Given this list of marker genes CCL19, NFKB2, REM1, BATF, IQSEC2, PSME2, STAG1, ZNF189, SAP30, HEG1, STOM, FAM131A, NME4, ZNF254, FOSL2, CCL8, USP11, TWIST1, THEMIS2, IDO1, DLEC1, IFITM1, IL6, LILRB2, HTRA1, RPL13P5, DYNLT1, HMBS, THBD (NCBI Gene Id 7056), PREP, SDS, PEPD, GNRH2, VAMP5, YIPF3, MX1, PPP1R3A, PFKP, MLLT11, NDST2, REPS1, NET1, TNF, RRAD, MLH1, DSC1, ETS1, CD2, IFT25, CDKN1A (cyclin dependent kinase inhibitor 1A), AP1G1, RIMS2, HLA-DPA1, AMHR2, PYGM (glycogen phosphorylase, muscle associated), GBP2, NCK2, LAMB3, RGS2, HNRNPM, SLC25A16, TPO, TXNIP, SECTM1, PLPP2, NR5A2, DUSP4, FOS, GRIA1, FDPS, ECH1, PTPN2, SERPING1, SLC37A4, TLR2, CBY1, SLC39A8, CD38, MUC6, ARR3, PTPRCAP, SCN9A, AP1B1, DLX5, WASF1, SPAG1, GBP1, GRIN2C, MKLN1, PSMA5, MAP3K4, UBE2L6, VEGFA, HBEGF, NIT1, SSB, CEMIP, CRYBB2 (crystallin beta B2), GABRB1, IRF1, APOBEC3F, RPA3, KMT2A, COMT, PADI2, IQSEC1, SLC35D2, HTATIP2, PCNX1, SKP2, KAT2B, CFB, KCNB2, TNFAIP2, RANBP2, EPHB4, SUSD5, CAP1 (cyclase associated actin cytoskeleton regulatory protein 1), MMP12, ZMYND8, C1QB (NCBI Gene Id 713), NDP, ANG, JAG1, PLAU, ADCYAP1R1, CXCL3, AIM2, ZKSCAN8, STEAP1, MCL1, AMPD2, DUSP1, ISG20, SMAD7, GNB5, SORCS3, HOXC5, OVOL3, CPB1, RELA, PBX2, SLC18A2, ORC3, CCL20, SBNO2, INPP5B, PDGFA, VPS9D1, VDAC2, TNFAIP6, RIN1, MMP1, CXCL10, TNFAIP3, ARHGAP5, STAT4, TSC22D3 (NCBI Gene Id 64477), PARD6B, STAU1 (NCBI Gene Id 6780), INPP4B, OPTN, GLUL, TXNL4A, ZNF44, CD1D (CD1d molecule), SLC16A4, CXCL13, EPB41L3, SP110, MTF1, CASP4 (NCBI Gene Id 837), KCNF1, IL15RA, RAB31, CEACAM7, PTGS2, UCP2, ZFP36, CASR, PTGES, MMP10, CFLAR, IL10RB, GCH1, PSMB9, ABCC10, YKT6, CLCA2, SPINK4, CCL5, NME1, COASY, ZNF510, SERPINB1, STK4, CXCL1, SASH3 (SAM and SH3 domain containing 3), PPP1R13B, here is a description of the gene set: Genes down-regulated in comparison of macrophages exposed to L. donovani versus macrophages exposed to M. tuberculosis. Human Gene Set: GSE360_L_DONOVANI_VS_M_TUBERCULOSIS_MAC_DN from publication Chaussabel D, Semnani RT, McDowell MA, Sacks D, Sher A, Nutman TB (PMID 12663451) species: Homo sapiens Monocyte-derived dendritic cells (DC) and macrophages (MΦ) generated in vitro from the same individual blood donors were exposed to five different pathogens, and gene expression profiles were assessed by microarray analysis. Responses to Mycobacterium tuberculosis and to phylogenetically distinct protozoan (Leishmania major, L. donovani, Toxoplasma gondii) and helminth (Brugia malayi) parasites were examined, each of which produces chronic infections in humans yet vary considerably in the nature of the immune responses they trigger.